The following is a description of a gene set: Human Gene Set: GOBP_REGULATION_OF_CELL_DIVISION Any process that modulates the frequency, rate or extent of the physical partitioning and separation of a cell into daughter cells. studied in species Homo sapiens, and this is the list of marker genes: OPN1LW, ENTR1 (endosome associated trafficking regulator 1), FGFR2, YME1L1, KIF13A (kinesin family member 13A), WNK1, BTC, CALM2, TGFB1, MACC1, OR1A2, VEGFC, ARF6 (NCBI Gene Id 63379), RXFP3, CDC14C, AURKA, RACGAP1, CDC14B, LBH, YEATS2, ZZZ3, CDC25B, DLL1, KAT2B, FGF4, CENPV, TP63, BIRC6, PRDM15, BCL2L1, CCDC66, IL1B, KIF23, ECT2, NCOA3, YBX1, HTR2B, INTU, NLRP5, ZFYVE19, ESRRB, RACK1, DRD2, SFN, PRPF40A, OR2A4, WDR5, PKN2, NAP1L2, KDF1, DRD3, FGF6, TADA3, EFHC1, FGF1, SPAST, KAT2A, PRKCE, SIRT2, BBS4 (NCBI Gene Id 585), TEX14, MYO19, KIF3B, GKN1, DCDC1, CHMP3, SSTR5, THBS4, PPBP, CDC14A, CETN2, INCENP, SETD2, BLM, VEGFA, FGF9, TGFA, GPR15LG, TXNIP, KAT14, CSPP1, PROK1 (NCBI Gene Id 84432), PDXP, CUL3, KIF20A, CCP110, OOEP, FGF7, CDK2AP2, PLK3, MYC, CXCR5 (C-X-C motif chemokine receptor 5), E2F8, ITGB1BP1, ATXN10, INSC, GIPC1, WNT9B, GAREM1, SGF29, KLHL9, RHOA, ZFYVE26, TADA2A, PAX6, CAT, MRGPRX2, PRC1 (protein regulator of cytokinesis 1), NUP62, MAP10 (microtubule associated protein 10), POLDIP2, TGFB3, AHCTF1, DR1, TAS2R13 (NCBI Gene Id 50838), IL1A, VPS4A, VEGFB, SVIL, FGF8, PDGFD, PDGFB, CIB1, BIRC5, OPN1MW, SFRP2, KLHL21, PLK1, TAS1R2, CDCA8, FSD1, ASPM, SUSD2, PTCH1, PIN1, PIK3C3, CALM3, TLE6, SMYD5, SHH (NCBI Gene Id 6469), ANKRD53, PKP4, BECN1, PIK3R4, AURKB, MIR145, BRCA2, FGF3, MAP9, PDGFC, PGF, CDC6, MDK, EVI2B, RAB11FIP4, MLLT3, UVRAG, CHMP4C, RAB11FIP3, TAL1, POU5F1, GIT1, IGF2, KIF18B, PDGFA, EXOC7, OPN1MW2, OSM, AURKC, HDGF, SOX17, CALM1, E2F7, CDC42, KLHL13, ZNF16, TGFB2, CIT, MBIP, RAB11A, FGF5, PTN, VEGFD, NKX3-1, KIF20B, KIF14, FGF2, SH3GLB1, EREG